Given this list of marker genes NR3C1, CREBRF, PER1, CRY2, NEDD4, JAK2, PPP5C, LMO3, BMAL1, PHB1, CRY1, CLOCK, YWHAH, CALR, here is a description of the gene set: Human Gene Set: GOBP_NUCLEAR_RECEPTOR_MEDIATED_CORTICOSTEROID_SIGNALING_PATHWAY studied in species Homo sapiens A nuclear receptor-mediated signaling pathway initiated by a corticosteroid binding to an intracellular receptor of the nuclear receptor protein family, and ending with regulation of a downstream cellular process, e.g. transcription.